The following is a description of a gene set: studied in species Homo sapiens A cellular process that results in the biosynthesis of constituent macromolecules, assembly, and arrangement of constituent parts of ribosome subunits; includes transport to the sites of protein synthesis. Human Gene Set: GOBP_RIBOSOME_BIOGENESIS, and this is the list of marker genes: USP16, RPL5, DKC1 (NCBI Gene Id 1736), RPL35, NOB1, RCL1, ZNF622, RPL27, NOL8 (NCBI Gene Id 55035), YBEY, SPOUT1, MTG1, ZNHIT3, DNTTIP2 (NCBI Gene Id 30836), GNL3L, RPL24, RPS12, XPO1, TFB1M, RPP30, PPAN, DDX49, RAN (RAN, member RAS oncogene family), WDR3, CINP, UTP14C, FDXACB1, IMP4, EXOSC3, C1D, RPS15A, RPLP0, MDN1, METTL16, GTPBP4 (NCBI Gene Id 23560), CUL4B, UTP20, SURF6, EXOSC8, NSUN3, C1orf131, ISG20, AIRIM, NGDN, URB2, EIF1AX (NCBI Gene Id 83754), TRMT61B, RPS16, GTF2H5, MAK16, DHX29, WBP11 (NCBI Gene Id 51729), RPP25, RIOK3, DDX28, UTP6 (UTP6 small subunit processome component), EXOSC2, GEMIN4, DDX17, RPS27L, GTPBP10, DDX51, KRR1, LTO1, LSG1, DDX3X, EXOSC7, RPS9, EFL1, EXOSC6, RPP38, METTL25B (methyltransferase like 25B), RPS7, RPL11, EIF2A, RPS24 (NCBI Gene Id 6229), CDKN2A, RRP9, NSUN4, REXO1, DIMT1, MTERF3, RRP7BP (ribosomal RNA processing 7 homolog B, pseudogene), UTP11, EIF6, RBM34, RPS21, VCX, SRFBP1, RPSA2, MIURF, MCAT, RPL7A, DDX27, RPLP0P6, FRG1, MTG2, REXO5, HEATR3, PNO1, RCC1L, RPS3A, METTL15P1, MRPS2, USP36 (NCBI Gene Id 80160), NPM1, NOC2L, DDX52, TENT4B, KRI1, WDR75, DROSHA, LTV1, NLE1, METTL15, UTP4, AATF, NAT10, BRIX1, PWP1, FTSJ3, GNL2, EIF4A3, MTREX, DDX56, MPV17L2, DDX21, NVL, NOC4L, DHX37, FBLL1, RNASEL, RRP15, RPS27A, EIF5B, GAR1, ZCCHC4, RSL24D1, FBL, ERCC2, SDE2, RPL35A, TSR1, RPS19, NOP10, DDX54, MRTO4, MPHOSPH10, BMS1, RPS15 (ribosomal protein S15), RRP36 (ribosomal RNA processing 36), RPUSD2, IMP3, XRN2, RPUSD1, PELP1, RPL7, NOL7, RPL14, ERAL1, SNU13, NHP2, NOP14, RPSA, CHD7 (chromodomain helicase DNA binding protein 7), LSM6, RRP7A, NPM3, RBM10, MALSU1, EXOSC9, RPS14, URB1, AFG2A, NOP53, NSA2, DDX47, NSUN5, WDR74, RPS4X, SLX9, MRPS7, WDR18, RPS8, EXOSC4, BOP1 (BOP1 ribosomal biogenesis factor), RPS27, MPV17L, LYAR, RPS11, ABT1, NOP16, ERI1, NUDT16, RPL7L1, WDR55, NMD3, EMG1, UTP14A, NOLC1, PIN4, RPF2, FASTKD2, ZNHIT6, NIP7, CUL4A, RPF1 (NCBI Gene Id 80135), UTP3, MRM1, FAU, MYG1, SBDS, RPS5, NGRN, NOP56, DHX30, TSR3, EXOSC10, TBL3, RPS17, AFG2B (AFG2 AAA ATPase homolog B), GTF3A, DIS3, REXO4, YTHDF2, TRMT2B, TRMT112, BYSL, PDCD11, RIOX2, MTERF4, SUV39H1, UTP15, SIRT7, EIF5, GREB1L, POP7, RBIS, ISG20L2, FCF1, NUP88, PAK1IP1, C1QBP, HEATR1, RPS28, REXO1L1P, GLUL, DDX18, TFB2M, PIH1D1, NOL9, TSR2, SART1, ESF1, RPL10L (ribosomal protein L10 like), PES1, WDR43, METTL17, RPS25, PIH1D2, POP4, UTP23, MRM3, GRWD1, RRP1B, ZNF658, WDR46, WDR36, MRM2, RRS1, KAT2B, METTL5, EXOSC1, DCAF13, NOL6, TMA16, ZNF593, NOP9, NOP2, XRCC5, POP5, RPS6, RPL38, PA2G4, RIOK2, RBFA, RPP40, RRP1, NOP58, RPS13, MYBBP1A, EBNA1BP2, SDAD1, ABCF1, RIOK1, BUD23, PRKDC, RRN3, RRP8, NAF1, NOL11, UTP25, WDR12, METTL18, NOL10, DDX31, RPL26 (NCBI Gene Id 6154), EXOSC5, RPS19BP1, RPS23, NOA1 (NCBI Gene Id 84273), MPHOSPH6, PWP2, RPL26L1, RPUSD4 (NCBI Gene Id 84881), UTP18, AK6, LAS1L, DDX10, NOM1